The following is a description of a gene set: species: Homo sapiens Human Gene Set: REACTOME_CLASS_C_3_METABOTROPIC_GLUTAMATE_PHEROMONE_RECEPTORS Class C/3 (Metabotropic glutamate/pheromone receptors), and this is the list of marker genes: TAS2R31, GABBR2, GRM4, TAS2R4, GRM8, CASR, TAS2R20, TAS2R39, TAS2R3, TAS2R60, TAS2R46, TAS2R16, GRM3, TAS2R14, TAS2R1, GRM7, GRM2 (NCBI Gene Id 2912), TAS2R30 (NCBI Gene Id 728338), TAS1R2, GABBR1, GRM5, TAS2R38, TAS2R13, TAS2R40, TAS1R1, TAS2R42, TAS2R41, TAS2R5, TAS2R8, GPRC6A, TAS1R3, TAS2R43, TAS2R19, TAS2R9, TAS2R50, TAS2R10 (NCBI Gene Id 50839), TAS2R7, GRM1 (glutamate metabotropic receptor 1), GRM6